The following is a description of a gene set: species: Mus musculus Mouse Gene Set: GOMF_PHOSPHATIDYLINOSITOL_4_5_BISPHOSPHATE_PHOSPHATASE_ACTIVITY Catalysis of the reaction: 1-phosphatidyl-1D-myo-inositol 4,5-bisphosphate + H2O = 1-phosphatidyl-1D-myo-inositol phosphate + phosphate., and this is the list of marker genes: Ptpmt1, Inpp5b, Synj2, Inpp5k, Pip4p2, Inpp5j (inositol polyphosphate 5-phosphatase J), Ptprq, Pip4p1, Inpp5d, Synj1, Ocrl, Inpp5e, Fig4